Given this list of marker genes ADGRF5, SRPK2, DGKZ, VRK2, FBLN1, NAGK, PFKL, PGAM1, TLK2, CTF1, DGKH, MTMR1, ADCY5, WEE2, COASY, ENTPD5, UGDH, NUDT9, CREB1, NDUFS1, GPX4, PRR5L, DDHD1, ACSM4, TARDBP, TPD52L1, GSKIP, PPP1CB, EIF2AK2, RAB38, OSBP, PRKACB, PC, BARD1, IMPDH1, NAXE, PLCH1, IGBP1, PPP2R2A, HSPB1, FBXW11, PGK1 (phosphoglycerate kinase 1), AK5, NDUFS3, NUDT16, HRG, KIT, TGDS, PEMT, MAP3K1, CD80, BLOC1S6, XBP1, MOB1B, STK3, DYRK1A, ATP5F1C, DHODH, CAMK2D, CKM, POMK, CARD14, NSD1, SERINC5, THBS4, FLT4, G6PC3, SMPDL3B, PLA2G2D, DUSP9, CENPE, EXTL2, PPP1CA, IL12A, PTPRT, DYRK2, LDLR, ADM2, UCHL1, LPCAT1, FGF10, GUCY2F, MYO3A, APOC2, DGAT2, MAPKAPK5, BRAT1, IGBP1C, CNTF, KDM4D, LETMD1 (NCBI Gene Id 25875), MAP3K20, MTMR12, FGF19, ALOX15, AURKC, SLC25A10, ATP5F1A, CD244, CMPK2, IL6, HNRNPU (NCBI Gene Id 3192), LGALS13, NOCT (nocturnin), RTRAF, DUSP8, PDCD10, MPPE1, IRGM, RIPK1, ARNT, PIGA, SCARB1, EPHX2, LRRK2, EPHB4, MAPK9, ACOT2 (acyl-CoA thioesterase 2), APP, MAPK3, ALDOC, ZGPAT, INPP5K, HCST, GDA, YWHAG, INPP5B, ELOVL5 (NCBI Gene Id 60481), PPP1R15B, PTPN7, NEK11, CCNYL1, GFPT1, SYAP1, SLC25A18, TOLLIP, IL4, PGAP4 (post-GPI attachment to proteins GalNAc transferase 4), CD4, PIGZ, NDUFS6, STK11, INSRR, GLMN, ADCY2 (adenylate cyclase 2), ORMDL1, INSR, ENTPD3, PRKX, SYNJ2, QPRT, GRK7, FLVCR1, MAPK1, MDH2, XRCC6, ETNPPL, SRD5A3, IFNG, ACOT7, CKB, PTHLH, ITPKA, CHKB, PLA2G4F, NUDT11, UHMK1, LIPC, ENTPD8, TENM1, ATP1B1, ME2, CHRM5, CASS4, PAK2, BECN1, LDHC, IMPDH2, DCAKD (NCBI Gene Id 79877), AK8, CHMP6, LEP, CNKSR3, S1PR2, DDR2, ATP5F1E (ATP synthase F1 subunit epsilon), CEP85, RPS6KA5, NDUFS4, SMG1, MVK, ABCA2, ANGPT1, SULT1C3, EP300, ADPGK, CSF1R (colony stimulating factor 1 receptor), GGPS1, TBX1, NEIL2, PIK3R6, PDHB, PLEK, TTC7B, WNK2, PKLR, MAP4K4, PLAUR, ACYP2, MLXIPL (NCBI Gene Id 51085), RNASEL, FLOT1, SAMHD1, ENTPD2, NLRP2B, GNPNAT1, DUSP18, NDUFA2, KSR1, ATG14, GPAT4, EPHA3, ADCY7, FBP1, SCP2 (sterol carrier protein 2), TYMS, UXS1, MMD, MYLK, TXK, TAF1, ABHD4, PLK2, TSPO, GUCY2C, ELOVL7, NEK10, TBCK, HSPA8, NUDT8, IPPK, CSNK1G2, INPP5E, CNOT9, PKM, TNFAIP8L3, ITLN1, SLC19A3, PGLS, GALK1, CARD11, PLCB2, STK38L, PANK1, PIGF, BTRC, LIPE, ACACB, PPP2R3A, INHA, CSNK1E, SLC17A2 (solute carrier family 17 member 2), ETNK2, PLPPR4, PAICS, RIPK2, SELENON, PCYT2, GNPDA2, PDK2, TECR, NDUFV2, MINPP1, PRKY, SLC25A11, PIGB, PPP3CC, PTPRF, RORA, CTDP1, SFRP2, PIGS, NDUFA13, GARS1, CLN8, ELOVL2, PDE8B, MAPK8, CHPT1, ACSM6, OSBPL8, PLAAT2, PLA2G6, CHKA, CIB1, UGGT2, TKT, PPP1R12A, NMRK1, NDUFA1, ANGPTL3, CDS2, SDHAF2, ALDOA, AURKA, PIP4K2A, OGG1, PARG, DDR1, GSK3A, MT-ND1, ZNF622, APRT, MAP3K7, PLPP4, TTC7A, HK3, PRKCE, CLK2, HIPK2, MGAT1, DUSP15, FYN, THEM5, MIR30C1, ENTPD4, JAK1, PLPP3, NADK2, ATP5PB, PLPP5, ARHGEF5, ACLY, SNCA, NUDT3, PPM1M, ABL1, TNFSF18, IQGAP1, SERINC4, LDB2, INPP1, FER, TOM1L1, ELANE, PKN3 (NCBI Gene Id 29941), MAPK10, PLBD2, DNPH1, PPCDC, RPE, DMTN, ENO3, FABP5, PLCH2, PIP5K1C, ARHGEF2 (Rho/Rac guanine nucleotide exchange factor 2), CADM4, IRAK1, PDK3, SPATA18, LIPG, AKT3, PIP5KL1, PSMD10, PFKFB4, MAP3K5, IL31RA, PLPPR1, LPGAT1, MT-ND4L, PGP, GCKR, TNK2, UPP2, STK17B, GIT1, EPM2A, GOT1, MERTK, GRK1, GALR2, ELOVL4, SDCBP, HGS, PDGFA, ACSS2, MTHFD2L, ROPN1L, DUSP1, ODAM, MAK, THY1, DNAJC30, KLHL31, EFNA5, IPMK, SLC4A1, PRPS1L1, TP53RK, DGKG, SLC44A2, B4GALNT2, ABCA3, PLA2G4D, NNT, PLD1, RALB, CLIP3, ENTPD7, CCNK, ACOT6, SPHK2, PLCB3, CACUL1, SSH1, GAPDHS, ACSM2B, HTR2B, FGF16, PGM1, SPHK1, PIGY, CDKN1A, RUNX3, PTPRH, CBR4, MIF, CETP, SH3YL1, PKN2, STOML2, PPP3CA, DIPK2A, TJP2, MDH1B, ALDH1L2, MAPDA, TPTE2, PLA1A, PPEF2, AK4, FOXK1, PIKFYVE (phosphoinositide kinase, FYVE-type zinc finger containing), DPM3, SLC2A6, GFUS, TSG101, MBOAT2, SLC25A25, PIK3C2B, VAPA, TSPYL2, NEK2, TSSK1B (testis specific serine kinase 1B), SDHC, MAPK8IP1, TIMM50, SOCS5, HK2, PRKAG1, SNF8 (SNF8 subunit of ESCRT-II), DHDDS, CARD10, PI4K2B, HACD2, OGDH, NMNAT1, ABHD16A, DERA, GART, IP6K3, TFAP4, KAT2B, RPTOR, TGFB1, TDO2, PDE2A, ABI3, PRXL2C, DUSP11, FLAD1, DYRK1B, SMPD4, PTPRD, ENSG00000293349, LIF, AREG, PRKCQ, MIR675, ILF3, FITM2, BAD (BCL2 associated agonist of cell death), DBNDD2, TPST2 (NCBI Gene Id 8459), BCKDK, HMGA2, PIGQ, DUSP7, PLXNB2, GK2, PLA2G1B, CALCA, UBE2K, THTPA, FAR1, NUDT17, PELI2, PLA2G2F, ITGB2, PDCD4, ACSM2A, NDUFC2, MAP2K2, GUCY2D, PPM1D, GOT2, ACSL6, RAF1, ABHD5, DPYD, BMP4, PRTFDC1, PTK2, GTPBP1, PDE8A, UPB1, STK25, PICK1, PLK1, DAPP1, FIS1, CRLS1, PTPRC, PPEF1, EFL1, PGAM2, ABL2, FBH1, SBF1, GAPDH, BIRC6, IL15, AGAP2, CDC14B, TBPL1, CDC42BPB, NT5E, INPP5D, MTOR, SNRK (SNF related kinase), DUSP5, SESN2, BANK1, ADSL, PTPN2, ERBB4, PRKCB, DUSP12 (dual specificity phosphatase 12), TNKS, RNASEH2B, OGDHL, NKX2-1, IRAK2, NUDT7, PNLIPRP2, ABCC9, INPP5F, ELOVL3, BRSK1, UAP1, BPNT2, LIPA, RB1 (NCBI Gene Id 92728), TTBK2, AK1, MCCC2, ADAR, PHIP, PRPS1, CDC25B, CHEK2, IFNL1, NDUFA11, NDUFA6, PRKCA, PTPN18, DCK, RBL2, ITPA, NDUFA9, SDHB, PDK4, ASMTL, CCNE2, PLCL1, STK17A, HDAC4, PRKCH, PTPMT1, LDHB, SDHA, UCP2 (uncoupling protein 2), RPS6KA4, PTPN22, CD38, SYNJ1, IRAK3, PXK, THPO, CAMK2B, PAPSS2, MAP3K4, MAP3K10, GSK3B, SELENOI, KMO, PCSK9, RAC1, CHAT, DCXR, ABI1, PRKD1, TLR3, PIGO, CLSPN, DSCAM, PTPN5, TSSK4 (NCBI Gene Id 283629), C9orf72, MT-ATP6, STK16, FADS1, ENPP2, NDUFA10, EPHB1, CTBP1, FIGNL1, PTAFR, NHERF1, PLCB1, NPM1, INPP4A, MTMR14, DLST, PDP1, TP53, PIBF1, ACSM5, PDE5A, IDO1, COQ8B, FDFT1, CBFA2T3, TREM2, DYNLL1, PLSCR1, STAT2 (NCBI Gene Id 6773), RAN, HASPIN, AK3, HSPA1B, IP6K2, ENPP6, PRLR, TMSB4X, INCA1, PRPSAP1, PLA2G12A (phospholipase A2 group XIIA), PDE1A, GNPTAB, PLCG2, UQCC3, VRK1, CMPK1, MTMR9, SULT2A1, ABHD16B, BPNT1, TPX2, PTK2B, PLPPR2, RASIP1, DUSP21, DNAJA1, PTPRQ, CCNY, PAFAH1B1, AKTIP, ZNF16, PDE7A, DCLK1, ATIC, SLC44A3, MYDGF, NDUFB4, ADSS2, ABCA8, TGFBR1, SULT1A3, ABCC6, SULT2B1, ATP1A2, CDS1, PDE4A, CNOT7, SERTAD1, ATP5MK, SERPINB3, CLN3, SARM1, CDA, EPHA7, ATP5MC3, MTMR2, CCDC88A, VPS9D1, AGPAT3, NAXD, SLC17A4, NTRK1, UCK2, APLN, MAP3K13, MEX3B, CKMT1B, ACMSD, GALT, ROS1, NDUFB5, DIRAS3, DAPK2, HTATIP2, SAMSN1, MAST1, PRKG2, AMPD3, CDK9, PIGC, GADD45A, CORO1C, PCYT1A (phosphate cytidylyltransferase 1A, choline), RD3, PDHX, PIPSL, RAB23, TPST1, SSH2, PGAP1, MFSD2A (MFSD2 lysolipid transporter A, lysophospholipid), MT-ND4, PDXK, PPP5C, CPS1, PTPN21, ME1, PLA2G2A, WDFY2, PPP6C, PASK, ACSL4, ATP5IF1, BCCIP, G6PC2, DUSP4, STK26, OXSR1, SGK1 (NCBI Gene Id 6446), PLCE1, CSNK2A3, MTMR8, NME2P1, PDK1, MVD, ATP7A, FLT1, THBS1, PFN2 (profilin 2), ELOVL1, AGPAT5, CTSG, GALM, NDUFA12 (NCBI Gene Id 55967), NCOR1, MYH7, NADSYN1, DUSP13A, PPM1A (NCBI Gene Id 5494), UCKL1, PIPOX, OLA1, ACP6, NDUFC1, RRM2 (NCBI Gene Id 6241), NPPA, MYH8, NLK, PPM1E, NDUFS5, NT5C3B, TRAF4, PKDCC, PTH1R, ATP5PF (NCBI Gene Id 63498), HCK (HCK proto-oncogene, Src family tyrosine kinase), CDKN3, INS, GPD1, HMGCS1, GMFG, ADCY10, FBP2, DUSP6, CDK17, GPD1L (NCBI Gene Id 23171), INHBA, GIMAP7, BMP2, TCIM, PLA2G4A (NCBI Gene Id 5321), NUDT18, PFKM, GDPD1, RPIA, PRKAG2, NPPB, EFEMP1, ACSL5, PIGX, PLAA, INSM1, ZBTB20, UPRT, FGFR4, CLPX, PDE4D, PKMYT1, DNAJC19, PPAT, P2RX7, INPP5A, PPA1, GALE, PDCL3, FMO2, MBOAT7, PIK3R1, MYLK2, BEND3, NDUFB9, PMM1, ALOX15B, PLA2G12B, PLA2G7, FIG4, TKFC, RAPGEF2 (Rap guanine nucleotide exchange factor 2), NME6, DHX34, GDE1, KYNU, TNNI3K, NEK7, TRIB1, MPI, TNF, MOCS1, NUDT4B, NTRK2, NUDT13, PTPRS, SLC44A4, SLC30A5, PRDX3 (NCBI Gene Id 29017), SRMS, ATP6V0C, PTPRB (NCBI Gene Id 5787), ABI2, CYP2W1, CDKN1C, MT-ATP8, ADCYAP1R1, FN1, DPYS, ENO2, CASK, PLPP1, FCSK, OSBPL10, GPRC5A, MAP2K3, CMAS, DUSP3, PRKACA, AK2 (NCBI Gene Id 83165), PLK3, CTNS, EPHA2, PIP5K1A, DEPTOR, UPP1, NPPC, CD74, APOA2, ZBED3, TNFRSF10A, WNK4, LMO4, GPER1, NDUFA7, CDK16, GMFB, PIK3R4, PPP2R3B, PLAAT4, CAMK2A, DDIT4, LACC1, GFPT2, PANK4, PRPSAP2 (phosphoribosyl pyrophosphate synthetase associated protein 2), AMPD2, PTPN6, ALDH1L1, RAP1A, OSM, MAP3K11, CDKN2A, KDR, ALPI, MCM7, NUPR1, SULT1A1, CKMT1A, NDUFB2, TNFSF15, FDPS, IDO2, EGF, ACOT4, PDGFB, MTMR11, HERC5, SRPK1, GCK, CDK5R2, ARAF, PANK3, NMRK2, ROCK1, NEK6, ITPK1, UNC119, TAOK3, TAF7, AASS, ETNK1, PDGFRA, GUCA1ANB-GUCA1A, NRG1, ARL2, ACP4, FGF18, PRKG1, PMM2, PPP2R3C, PIGU, PGS1, PPP2CB, PTPN13, NEK1, TALDO1, PTDSS1, PIK3R3, HEG1, PFAS, DGAT1, CDK11B, PPP1R17, SLC35A1, CHEK1, STOX1, UNG, FGF7, CEP43, GMPR, MPC2, ATPSCKMT, PDHA1, MOCS2, EPHB3, PTPRN2, ACSBG1, GATA6, PIGG, IGFBP3, PIP5K1B, DGUOK, SIRT1, DPM2, DUSP23, PPP2CA, MTMR3, ACVR2A, PFKP, PRKAG3, UMPS, JAK2, ECT2, PLAAT5, PILRB, PGM3, PRDX6, HLA-DRB1, CDK10, PPARA, PDGFRB, NPR1, HTR2C (5-hydroxytryptamine receptor 2C), ABHD12B, ABHD12, RBL1, LRGUK, JAK3, SORD, STRADA, ALDOB, DCTPP1, GDPD3, DGKB, SLC52A3, FASN (NCBI Gene Id 2194), DOK7, FABP3, ADCY4, PGAM4, MBD4, CNP, EREG, HYCC1, MYCNOS, ENPP7, SFN, INPP4B, PDXP, EEF1A2, AK6, PPT2, SH3GLB1, ATP5MC2, NFS1, ABCD1, CDC42BPA, NANS, NAPRT, AGPAT4, AMDHD2, RAP2A, NMNAT3, MAML1, PPCS, EZH2, TRAF2, PLBD1, XYLB, DGKA, SGMS1, SNX9, CCNT1, STK10, ZBTB7A, PIH1D1, AGPAT2, PITPNM3, PPP1CC, ULK3, AMPD1, CWH43, BCL10, IDI2, NUDT5, UVRAG, OSBPL5, PIGN, XRCC5, ADCYAP1, SULT1E1, CKMT2, ERCC6, GALK2, SLC25A22, MARK3, AK7, SERINC2, GUK1, IL20, GPHN, WNK3, ACSL1, ABHD3, SERAC1, TIGAR, SUCLG2, PDE4B, PIP4P2, NANP, CSGALNACT1, MAP4K3, SMUG1, PRKCD, TPTE, DAPK3, EIF6, TP53I3, STK39, PIK3C2A, GRK5, PIK3CD, FITM1, CAMKK2, AGT, PHKG2, NUDT4, IL11, PDE10A, NME9, EFR3A, PFKFB2, TNFRSF10B, HACD1, PITPNM1, AKR1A1, PDE4C, SULT1A4, NME3, ATP5ME, DUSP26, TAMM41, EPHB2, WNT5A, MYH4, ADAM10, PTPN11, NUDT10, DUT, PPIP5K1, HYCC2, MAP3K6, PLA2G4B, ETAA1, MAGI3, ACSS1, NDUFB8, REXO2, DTYMK, RIPK3, TRIB2, PROM2, ISYNA1, NME1, MAD2L2, PAPSS1, DCTD, AFMID, NDUFB10, FAM3A, SULT1C4, MKNK1, ADAM17, DLG2, ACSF2, RAP2B, CTDSP1, FKBP8, MARK4, SIK1, NUAK1, LYN, PTEN, PRDX4, MINK1, CDK5RAP3, SDHD, DUSP28, ACSL3, PTPRU, PIK3CA, GTF2H1, SLK, SIRT6, PARP1, CDC37, PTPRZ1, DHTKD1 (NCBI Gene Id 79141), PGAP2, PNPLA6, NPRL2, PFKFB1, DSTYK, PLA2G15, MT-ND5, DUSP29, SPRY2 (NCBI Gene Id 10253), OCRL, PTPN4, LPCAT3, SGPP1, UCK1, NUDT19, BMX, ATP5MG, PIM1, PLCG1, SACM1L, HDHD5, STRADB, IER3, BCR, MT-ND6, SLC25A12, PPARD, SMPDL3A, ORMDL3, FGFR3, PLA2G10, MST1, ATP5MGL, CDC6, CCL2, RPEL1, ATP5MF, PRKAA2, MAPK15, ACOT9 (acyl-CoA thioesterase 9), MIDN, ADIPOQ, ATP6V1B2, DRD2, IDH2, PIK3CG, LIPI, RHOA, BPGM, DNM1L, VEGFA, ACSM1, VAC14, EPHA4, CHP1, HEXB (hexosaminidase subunit beta), SMG7, MST1R, PNPLA8, FES, SOCS4, CDK5R1, PIK3C3, ACTN3, C3, VEGFB, PPP4R1, LTK, DOLPP1, ITPKB, PDE9A, TSSK6, FGFR1, NUDT12, CHP2, AKT1, MVP, MECP2, GMPR2, ZAP70, ACSF3, MYH6, PLA2G5, BAAT, TRAF3IP1, SMPD1, PTH (NCBI Gene Id 5741), P2RY6, PINK1, TDG, PDE7B, PFKFB3 (NCBI Gene Id 5209), RACK1, NUDT14, CACNB4, STK33, PDPK1, RPS6KB1, DOLK, ULK1, CDK5RAP1, DLD, SMG8, WNK1, FIRRM, NOP53, SLC44A5, NMNAT2, NR1H3, CRYL1, STK4, CREBL2, DMAC2L, SMPD2, LCLAT1, NME2, GPRC5B, CAPN2 (NCBI Gene Id 824), PLCL2, PIK3C2G, HAAO, CHI3L1, PRKCI, EMP2, NRP1, CDK1, JMJD8, GNAI3, MAP4K2 (mitogen-activated protein kinase kinase kinase kinase 2), MMP9, TMEM38B, NT5C1A, ATP5MJ, SMG5, ADSS1, NUAK2, PKN1, NDUFB11, PIGV, ALS2, PTPN14, SNX6, NDUFS8, LDHA, PNPLA7, COQ8A, ACYP1, NPR2, AADAT, JTB, ADCY1, APC, GCDH, AK9, CDKL1, PTPRJ, RBKS (NCBI Gene Id 64080), KIF14 (NCBI Gene Id 9928), GUCY1A1, PLA2G3, GMPS, RAD17, ASPDH, TRIB3, MAP3K9, NUS1, APOA1, PLK4, CLK3, PLA2G2C, PRKAA1, CIMAP3, PHEX, CTPS2, ADA, HES1, SRC, FGFR2, TRPM7, RASSF2, YWHAZ, GNPAT, FOXK2, LIMK2, KALRN, OPA1, DIP2A, G6PC1, NAAA, PLA2G2E, FAM20A, DUSP16, LTF (lactotransferrin), PIM3 (NCBI Gene Id 415116, Pim-3 proto-oncogene, serine/threonine kinase), CDK2, PGAP3, PLCD1, TARBP2, DGKI, SGPP2, ATP5F1EP2, MMD2, PTPN12, IGF1, ABHD14B, ALK (ALK receptor tyrosine kinase), XDH, STAT3, GPAT3, GPAM, APOE, PIGT, ERG, CDK11A, MTMR10, SLC4A7, TYK2, ADCY8, FLCN, FAXDC2, ERN1, PIN1, KARS1, MELK, ACOT11, VCP, MLST8 (MTOR associated protein, LST8 homolog), CROT, MTMR7, PRPS2, PTPRK, PIGL, PHB2, PIGK, STK36, PLAAT3, ALPL, OXSM, ANKLE2, IBTK, PON1, CRIPTO, COX11, ENTPD1, IMPA1, LPL, MKNK2, P2RY1, RASGRP1, DGKQ, ACAT1, EGFR (NCBI Gene Id 1956), CACTIN, ACVR1C, IKBKB, DGKD, PRKDC, UGGT1, ARL2BP, FPGT, HSD17B4, RHOQ, SMO, RGS14, DYRK3, DUSP10, ADCY3, GPD2, HIPK3, CEMIP, NT5M, CDKN1B, TLR6, HMGCS2, SEMA4D, NDUFV3, TLK1, ACOT8, MATK, RRM2B, SLC27A2, NT5C, LILRA5, ATP5PD, HADHA, ENO4, GUCA1A, GUCY1B1, HIPK1, SULT1A2, KNDC1, HIF1A, ENPP3, FGF2, PARP9, CSPG4, RIOK2, PARD3, PLAAT1, DRD4 (dopamine receptor D4), MTCH2, ATF2, UGP2, CDC42BPG, ATP5PO, PAQR3, ACSBG2, LATS2, IDI1, CTDNEP1, SMG6, ENPP1, TEC, SGK3, FHIT, OC90, COL6A1, NTHL1, MTHFD1, GK5, DLAT, NTSR1, NOX1, PTPRR, DNAJC3, CTDSP2, TNIK, ABHD6, SUCLG1, ATP5F1D, PIGH, CCL11, SRPX2, ATP5MC1, SLC35A3, PRKN, MAST2, MARK2, ITPKC, GMDS, LPCAT2, OGT, FGF1, TOP1, CDK12, GLYCTK, PEAK1, C8orf44-SGK3, MACROH2A1, BLM (NCBI Gene Id 641), DUSP2, PARP14, VNN1, SGK2, PCK1, PI4KAP2, SIK3, PIGP, TRAF6, CDC25C, FLT3, TK2, DBI, GPAT2, ARRB1, ZC3H12A, RFK, GMPPB, PI4K2A, PI4KB, CEPT1, ATP5F1B, HDAC3, NADK, RRM1, TRIM6, SP7, HINT1, NDUFS7, LATS1, MT3, SIRT2 (sirtuin 2), AAK1, PPIA, PITPNM2, CILK1, ADARB1, MAP3K12, TERF2IP, PIP4P1, FBN1, MARK1, MYOD1 (NCBI Gene Id 4654), PPM1G, ANG, HSD17B12, ERN2, GNB3, MLYCD, ITGB1BP1, PIP4K2B (NCBI Gene Id 8396), NT5DC2, TSSK3, GPCPD1, GLYAT, NME7, CAB39, SYK, PRKCZ, URI1, MTMR6, GMPPA, PPM1B, RALBP1, PID1, NDUFB6, NUDT15, RARA, PLD2, CAD, RAP2C, GNE, PYCARD, LCAT, GPAA1, MAP3K21, CAMK1, GUCY1A2, PMVK, PLB1, NEIL1, ATM, SYNPO2, MTMR4, COPS8, NDUFAB1, FGR, DLG1, SLC25A13, GRB10, APOC1, STK38, NIBAN1, LCK, NEK3, BRAF (NCBI Gene Id 673), PNPLA3, GPLD1, PIK3CB, SGMS2 (NCBI Gene Id 166929), PRRT1, SPTLC1, S100A12, MT-ND2, PNPO, TREX1, GPI, NLRC5, NPTN, GAS6, ERBB2, RYK, PISD, DUSP13B, PIGW, DIRAS2, TRIM27 (NCBI Gene Id 5987), ELOVL6, IFNL4, CSNK1A1, PI4KA, EIF2AK4, TAFAZZIN, PIGM, DIRAS1, CDIPT, KHK, MORC3, LHPP, CCNG1, PPP3CB, PLA2G4C, PKD1, PPT1, DMPK, GNPTG, ERRFI1, SULT1B1, SMPD3, SUCLA2, PTPN9, PTPRE, AGK, ROPN1, LDB1, ACO1, EFR3B, PGK2, CAMK4, PRKD2, MMUT, CSNK2B, NR1H2, MDH1, MBOAT1, PPIP5K2, NAPEPLD, SPDYA, LHCGR, AIDA, FASTK, IL18, SLC35C1, PNP, ANKH, CMAHP, NDUFA5, PLPPR3, SAMD8, MOK, ACOT1, ATP6V1A, LIMK1, ULK2, CEACAM1, ROCK2, SPTLC2, MFSD8, PLCB4, FUT8, PDHA2, HK1, TK1, PGD, ACACA, TPK1 (thiamin pyrophosphokinase 1), ERC1, CSK, NDUFV1, AGPAT1, MAPK4, ZNF268, NT5C1B, EEF2K, ADK, INPPL1, FUOM, PRKD3, PTDSS2 (NCBI Gene Id 81490), HTR2A, KCTD20, MPP1, MTM1, NME5, ACSM3, SHMT1 (NCBI Gene Id 9316), HSPA1A, FGGY, TAB2, NIM1K, CSNK1D, EIF2AK1, SHPK, TRIM63, NEDD9, EFNA1, SLC25A19, ACVR1B, NT5C3A, CDC25A, MOCS3, NT5C2, SLC44A1, ENO1, LCP2, APOA4, NDUFB1, SRCIN1, PTK6, SLC4A4, PLPP6, WARS1, NFE2L1, PLA2G4E, SASH1, LACRT, PSEN1, NDUFS2, PCYT1B, ANGPT4, ATP6V1B1, DDRGK1, HTD2, TNFRSF18, ZFYVE28, IP6K1, MAP3K8, NAMPT, NDUFB7, MAP3K3, SLC20A1, ACP3, AKT1S1, MOCOS, NUDT2, G6PD (NCBI Gene Id 83159), HKDC1, FAM20C, TNK1, TMEM150A, PPA2, RPS6KA1, TPI1, HPRT1, TBK1, MFN1, DYNAP, STK24, ADORA1, PTPN1, MRNIP, COPS2, TSSK2, CCNT2, MAPK6, PIM2, NME4, LAT, MUSK, MAP4K1, HMGCR, VPS25 (NCBI Gene Id 84313), PANK2, IMPA2, PIP4K2C, DAPK1, LMTK2, SIK2, PROCA1, RARRES2, ZFP91, GK, FZD7, NDUFA3, PLPP2 (phospholipid phosphatase 2), IL21, PUDP, FKRP, BLK, IDH1, INPP5J, NR1H4, MYH3 (myosin heavy chain 3), H6PD, TMEM86B, CCNE1, TESK2 (NCBI Gene Id 96574), SLC19A2, CDK2AP1, UAP1L1, LIMCH1, LPIN1, AJUBA, ANTKMT, TTBK1, SERINC1, PIK3R5, MCEE, ROPN1B, MAP2K1, BCL2L13, SFRP1, NDUFB3, ACOT12 (acyl-CoA thioesterase 12), ADCY6, LPCAT4, CTTNBP2NL, ABHD8, DGKE, NDUFA8, MT-ND3 (mitochondrially encoded NADH:ubiquinone oxidoreductase core subunit 3), CTPS1, TYMP (NCBI Gene Id 4334), BRSK2 (BR serine/threonine kinase 2), PARK7, DEFB114, DGKK, DPM1, TNS2, ENG (NCBI Gene Id 2022), BTK, IGF1R, ADCY9, NEK4, PLPPR5 (phospholipid phosphatase related 5), FAR2, IL34, LIMD1, CD300A, PKIA, SLIT2, MEN1, AVPR1B, LIPH, RSPO1, GNPDA1, here is a description of the gene set: species: Homo sapiens Human Gene Set: GOBP_PHOSPHORUS_METABOLIC_PROCESS The chemical reactions and pathways involving the nonmetallic element phosphorus or compounds that contain phosphorus.